The following is a description of a gene set: The whole of the physical, chemical, and biochemical processes carried out by multicellular organisms to break down ingested nutrients into components that may be easily absorbed and directed into metabolism. Human Gene Set: GOBP_DIGESTION species: Homo sapiens, and this is the list of marker genes: TLR4, LIMA1, PRSS1, ENPP7, COPA, CCK, NR1H2, CHIT1, CHRM3, LDLR, FABP2, ADRA2A, CLDN15, PGA5, APOA2, EZR, EPB41, KCNN4, SLC26A6, SNX10, APOA4, OXT, CYP39A1, IL10RA, GCNT3, PPP3CA, CLDN2, UGCG (NCBI Gene Id 7357), NPSR1, ABCG5, PBLD (phenazine biosynthesis like protein domain containing), PRSS2 (serine protease 2), VDR, CRH, PGA4, SOAT2, SLC46A1, TFF2, MUC13, LPCAT3, PGC, WNK3, STK39, APOA1, VSIG1, NPPC, CEL, UCN2, NPR2, DAO, NEGR1, CYP8B1, VIL1, SLC9A4, TYMP, ABCB1, SCT, CD36, RBP4, HTR4, SLC22A5, PRAP1, PNLIP, AQP1, TFF1, CLPSL2, TIFAB, SCARB1, AKR1C2, MDK, FGF10, CHRM5, CRACD, MOGAT2, HIP1R, MUC6, GHRL (NCBI Gene Id 51738), LIPA, PTGER3, PNLIPRP2, LRCOL1 (leucine rich colipase like 1), PLS1, NKX2-3, HRH2, DCANP1, AKR1D1, ZNF830, STATH, MUC4, LEP, UCN3, CHRM1, COMT, CAPN9, AMY2A, CTRB1, NMU, HEPH, NOD2, TFF3, AKR1C1, STRAP, SGK1, AQP5, HAMP, PPARGC1A, PGA3, SERPINA3, CCKBR, SOX9, NR1I2, F11R, SLC4A9, ABCG8, OPRK1, SLC5A1, CLPS, ACO1, ASAH2, SLC2A5, PRSS3, TJP2, MUC2, NR1H3, NPC1, NPC1L1, GHSR, INAVA, SST, ARX, NEUROG1, CTRB2, IREB2, TLR9, IL17A, CLPSL1, GKN1, PIR, WNK4, CHIA, NEUROD1, SI, SLC26A7, WNK1, KCNQ1